The following is a description of a gene set: Human Gene Set: GOBP_REGULATION_OF_INTRINSIC_APOPTOTIC_SIGNALING_PATHWAY_IN_RESPONSE_TO_HYDROGEN_PEROXIDE studied in species Homo sapiens Any process that modulates the frequency, rate or extent of intrinsic apoptotic signaling pathway in response to hydrogen peroxide., and this is the list of marker genes: MIR92A1, PARK7, MIR133A1, PINK1, RACK1, AKT1, TRAP1